The following is a description of a gene set: species: Homo sapiens Any process that activates or increases the frequency, rate or extent of the directed movement of charged atoms or small charged molecules into, out of or within a cell, or between cells, by means of some agent such as a transporter or pore. Human Gene Set: GOBP_POSITIVE_REGULATION_OF_MONOATOMIC_ION_TRANSPORT, and this is the list of marker genes: PLCG1 (phospholipase C gamma 1), FLNA, TRPV3, CAV1, CAMK2A, CNTN1, ADCYAP1R1, CASR, AHCYL1, P2RY12, GALR2, LGALS3, STK39, CCL3, HTT, CXCL12, P2RX3, TACR2 (NCBI Gene Id 6865), FFAR1 (free fatty acid receptor 1, NCBI Gene Id 2864), TESC, HEPH, FXYD5, CHP1, PLA2G1B (NCBI Gene Id 5319), CD19, ATP2C2, ISL1, GRIN1, TRPV2, WFS1, NOS1AP, ABL1, PRSS8, P2RY6, FXYD3, TRPA1, BAK1, HCRT, CCL4, ATP1B1, STIM1, TMSB4X, THY1, CXCR3, CFTR, NTSR1, P2RX1, CREB3, SCN3B, CRACR2A, LRRC26, CCL2, IFNG (interferon gamma), SCN5A, DRD1, STIM2, CACNB2, CNKSR3, CACNB3, ACTN4, ABCC8, EDN1, ADORA1, MYLK, UCN, TRPC3, KCNH2, HOMER1, PPP3CB, OPRK1, ACTN2, TRPC1, MIR21, MIR1-1, AKAP5, GPD1L (NCBI Gene Id 23171), FGF13, PDGFB, GPER1 (NCBI Gene Id 2852), FXYD2, ATPSCKMT, EDN3, F2R (NCBI Gene Id 2149), CHRM1, CCR1, TCAF1, FXYD6, ANO6, LEP, VMP1, LRRC52, AKAP7, NPPA, PDPK1, CASK (NCBI Gene Id 8573), SCN1B, PPP3CC, NIPSNAP2, LCN2, G6PD, ANK2, KCNC1, STAC3, F2RL3, ADRA2A, ASPH, MIR210, CASQ1, KCNC2, LILRA5, ATP2A1, EDNRA, STAC, MS4A1, AMIGO1, IL13, KCNE1, PKP2, KCNN4, AKT1, CRH, BDKRB1, STC1, P2RX7, CXCL10 (NCBI Gene Id 3627), HAP1, MLLT6, STRIT1, P2RX4, ATP2B1, MCHR1, LACRT, WNK3, TRPC6, CAPN3, KCNIP2, CTSS, COX17, FXYD7, CCL5, FGF12, P2RX5, NKX2-5, GAL, ATP1B3, KIF5B, GCG, P2RY1, FXYD1, ATP1B2, TOR2A, STIMATE, LRRC55, CACNA1D, FXYD4, XCL1, ANK3, KCNE5, KCNQ1, APLNR, FHL1, PPP3R2, AKAP6, SLC6A4, TSPO, SNCA, PDGFRB, SRI, GRM6, CD4, SCN4B, CXCL9, GSTO1, F2 (coagulation factor II), WNK2, NOS1, SCN2B, TREM2 (NCBI Gene Id 54209), ORAI1, JPH2, NPSR1, LILRA2, DLG1, PPP3R1, CXCL11, STAC2, CX3CL1 (C-X3-C motif chemokine ligand 1), P2RX2, BAX, CEMIP, PPP3CA, LRRC38, KCNJ2, LPAR3, FXYD6P3